The following is a description of a gene set: Systems biology is an approach to comprehensively study complex interactions within a biological system. Most published systems vaccinology studies have utilized whole blood or peripheral blood mononuclear cells (PBMC) to monitor the immune response after vaccination. Because human blood is comprised of multiple hematopoietic cell types, the potential for masking responses of under-represented cell populations is increased when analyzing whole blood or PBMC. To investigate the contribution of individual cell types to the immune response after vaccination, we established a rapid and efficient method to purify human T and B cells, natural killer (NK) cells, myeloid dendritic cells (mDC), monocytes, and neutrophils from fresh venous blood. Purified cells were fractionated and processed in a single day. RNA-Seq and quantitative shotgun proteomics were performed to determine expression profiles for each cell type prior to and after inactivated seasonal influenza vaccination. Our results show that transcriptomic and proteomic profiles generated from purified immune cells differ significantly from PBMC. Differential expression analysis for each immune cell type also shows unique transcriptomic and proteomic expression profiles as well as changing biological networks at early time points after vaccination. This cell type-specific information provides a more comprehensive approach to monitor vaccine responses. Genes up-regulated in myeloid dendritic cell 7d vs 0d in adults after exposure to 2011-2012 trivalent inactivated vaccine (A/California/7/09 (H1N1), A/Perth /16/2009 (H3N2), B/Brisbane/60/2008), time point 7D. Comment: Up-regulated DE RNA transcripts (up >= 1.5x) shared between both TIV-vaccinated donors from publication Hoek KL, Samir P, Howard LM, Niu X, Prasad N, Galassie A, Liu Q, Allos TM, Floyd KA, Guo Y, Shyr Y, Levy SE, Joyce S, Edwards KM, Link AJ (PMID 25706537) species: Homo sapiens Human Gene Set: HOEK_MYELOID_DENDRITIC_CELL_2011_2012_TIV_ADULT_7DY_UP, and this is the list of marker genes: KLRB1, S100A12, B3GNT7, BTLA, GPX7, MATK, PRKCH, ADAMTS10, ADORA1, CD2, CARD11, MSLN, CCDC65, SIGLEC6, TRBV7-3, CLEC9A, IDO1, TLE1, DPP4, LPL, SEPTIN3, BOLA2B, MACORIS, SEPTIN1, CCR5AS, KIT, PTX3